Given this list of marker genes WASF3, CTNNA2 (catenin alpha 2), CYFIP1, SPTB (spectrin beta, erythrocytic), CTTN, ITSN1, CFL1, CTTNBP2, DIXDC1, ITPKA, WASF1, CAP1, PRMT8, RHOA, PFN2, ABI3, PFN1, BAIAP2, AMOT, here is a description of the gene set: Human Gene Set: GOBP_MODIFICATION_OF_POSTSYNAPTIC_ACTIN_CYTOSKELETON studied in species Homo sapiens Any process that modifies the structure of a postsynaptic actin cytoskeleton.